Given this list of marker genes SLC25A51, XPNPEP1, ADAM10, IL12A, FRAT2, ADRA2A, ARL5A, SLC11A2, CERK, AKIRIN1, HERPUD1, B4GALT1, TXK (NCBI Gene Id 7294), CACNG1, FDX2, CLOCK, TTC7B, PAFAH1B3, TCP10L, RHOJ, SPIN1, POLM, DBNL, SLAIN1, HSPA2, POU2AF1, EYA3, GAS7, DUSP11, NCAPH2, IRF4, MYO5A, TCF12, FGF12, RELN, TAX1BP3, CSF2, PSAPL1, PRRG2, APOBEC1, FCRLA, RGS2, SPG21 (NCBI Gene Id 51324), ACSS1, C1GALT1, SKAP2, ECH1, EPHA3, TRIM11, IGSF10, PRM1, SELENOW, RB1, DTNA, CD1D, MYL4, EPS8, ACKR3, SLC1A5, SRP14, PTGER2, PIM2, BTG2, RBM17, SEC11C, CYB5R4, PTPRB, WTAP, PSME4, CCNG2, ERP29 (endoplasmic reticulum protein 29), MARCKS, DESI1, ACHE, EMID1, UBA52, KLHDC2, here is a description of the gene set: Up-regulated genes in the B lymphocyte developmental signature, based on expression profiling of lymphomas from the Emu-myc transgenic mice: the Small Pre-BII stage. Human Gene Set: MORI_SMALL_PRE_BII_LYMPHOCYTE_UP from publication Mori S, Rempel RE, Chang JT, Yao G, Lagoo AS, Potti A, Bild A, Nevins JR (PMID 18922927) species: Mus musculus The Emu-myc transgenic mouse has provided a valuable model for the study of B-cell lymphoma. Making use of gene expression analysis and, in particular, expression signatures of cell signaling pathway activation, we now show that several forms of B lymphoma can be identified in the Emu-myc mice associated with time of tumor onset. Furthermore, one form of Emu-myc tumor with pre-B character is shown to resemble human Burkitt lymphoma, whereas others exhibit more differentiated B-cell characteristics and show similarity with human diffuse large B-cell lymphoma in the pattern of gene expression, as well as oncogenic pathway activation. Importantly, we show that signatures of oncogenic pathway activity provide further dissection of the spectrum of diffuse large B-cell lymphoma, identifying a subset of patients who have very poor prognosis and could benefit from more aggressive or novel therapeutic strategies. Taken together, these studies provide insight into the complexity of the oncogenic process and a novel strategy for dissecting the heterogeneity of B lymphoma.